The following is a description of a gene set: Genes down-regulated in blood 3d vs 0hr in adults (18-45) after exposure to CN54gp140 adjuvanted with GLA-AF, time point 3D, administered i.m. from publication Anderson J, Olafsdottir TA, Kratochvil S, McKay PF, Östensson M, Persson J, Shattock RJ, Harandi AM (PMID 29535712) species: Homo sapiens Systems biology approaches have recently provided new insights into the mechanisms of action of human vaccines and adjuvants. Here, we investigated early transcriptional signatures induced in whole blood of healthy subjects following vaccination with a recombinant HIV-1 envelope glycoprotein subunit CN54gp140 adjuvanted with the TLR4 agonist glucopyranosyl lipid adjuvant-aqueous formulation (GLA-AF) and correlated signatures to CN54gp140-specific serum antibody responses. Fourteen healthy volunteers aged 18-45 years were immunized intramuscularly three times at 1-month intervals and whole blood samples were collected at baseline, 6 h, and 1, 3, and 7 days post first immunization. Subtle changes in the transcriptomic profiles were observed following immunization, ranging from over 300 differentially expressed genes (DEGs) at day 1 to nearly 100 DEGs at day 7 following immunization. Functional pathway analysis revealed blood transcription modules (BTMs) related to general cell cycle activation, and innate immune cell activation at early time points, as well as BTMs related to T cells and B cell activation at the later time points post-immunization. Diverse CN54gp140-specific serum antibody responses of the subjects enabled their categorization into high or low responders, at early ( < 1 month) and late (up to 6 months) time points post vaccination. BTM analyses revealed repression of modules enriched in NK cells, and the mitochondrial electron chain, in individuals with high or sustained antigen-specific antibody responses. However, low responders showed an enhancement of BTMs associated with enrichment in myeloid cells and monocytes as well as integrin cell surface interactions. Flow cytometry analysis of peripheral blood mononuclear cells obtained from the subjects revealed an enhanced frequency of CD56<sup>dim</sup> NK cells in the majority of vaccines 14 days after vaccination as compared with the baseline. These results emphasize the utility of a systems biology approach to enhance our understanding on the mechanisms of action of TLR4 adjuvanted human vaccines. Human Gene Set: ANDERSON_BLOOD_CN54GP140_ADJUVANTED_WITH_GLA_AF_AGE_18_45YO_3DY_DN, and this is the list of marker genes: CHMP2A (NCBI Gene Id 27243), SCAND1, ARAP3, PSMC1, HBP1, AFF4, WLS, ARPC1B, S100A4, AMDHD2, TMLHE, PARN, DPEP2, MAPRE1, ZAN, TTI2, PPP1CA, ACTG1, PSMD13, DNAJB12, WAS, KCTD2, RAI2, PGAM1, DNTTIP1, OSTF1, ATP6V1A, MAEA, ZNG1F, TRIM63, RAB7A, NUDT5, ATG4B, CORO1A